Given this list of marker genes SCARF1, SORL1, COLEC12, LDLR, MSR1, TREM2, STAB2, LIPC, PCSK9, CD36, CRP, SAMD1, CDH13, THBS1, STAB1, PLTP, SCARB1, here is a description of the gene set: species: Homo sapiens Binding to a low-density lipoprotein particle, a lipoprotein particle that is rich in cholesterol esters and low in triglycerides, is typically composed of APOB100 and APOE, and has a density of 1.02-1.06 g/ml and a diameter of between 20-25 nm. Human Gene Set: GOMF_LOW_DENSITY_LIPOPROTEIN_PARTICLE_BINDING